Given this list of marker genes Ccr1l1, Col6a1, Acvr2b, Sbds, Fosl2, Tmem38b, Pth1r, Pthlh, Bglap2, Comp, Ccn1, Runx2, Nfe2, Axin2, Matn1, Lox, Mef2c, Sox9 (NCBI Gene Id 70015, SRY (sex determining region Y)-box 9), Suv39h1, Tent5a, Aspn, Icmt, Ptgs2, Mgp, Acvr2a, Mia3, Gcm2, Ddr2, Adgrv1, Wnt11, Csf1r, Nfix, Bmp2k, Ostn, Fgfr2, Dnm3os, Lgr4, Wnt4, Txlng, Zmpste24, Asxl2 (NCBI Gene Id 75302), Gpc3, Actn3, Cd276, Fgfr3, Nbr1, Gpnmb, Ccr1, Smad3, Fzd9, Lep, Ift80, Fam20c, Gata1, Enpp1, Alpl, Ltf, S1pr1, Atp2b1, Hif1a, Duox2, Eif2ak3, Snx10, Pkdcc, Rxrb, Slc24a3, Twist1, Alox5, Col1a2, Lncpint, Prickle1, Ano6 (anoctamin 6), Cyp27b1, Sgms2, Atf4 (activating transcription factor 4), Phospho1, Ecm1, Minpp1, Bglap3, Ccdc154, Cer1, Gja1, Ercc2, Ank, Bglap, Slc20a2, Rflna, Fbn2, Asgr2, Tfap2a, P2rx7, Ltbp3, Pth, Alox15, Igf1, Vdr, Bmpr1b, Dlk1, Mepe, Ifitm5, Grem1, Gla, Srgn, Osr2, Ibsp, Notum, Acvr1, Spp1, Hoxa3, Clec3b, Mtss1, Rspo2, Phex, Fgr, Bmpr2, Nell1, Fgf23, Slc8a1, Sbno2, Ptn, Gpm6b (glycoprotein m6b), Bmp7, Fbxl15, Adrb2, Bmp6, Bmp4, Trpm4, Fkrp, Kl, Rflnb, Herc1, Rxra, Cst5, Smpd3, Isg15, Bcor, Rogdi, Wnt10b, Bmpr1a, Osr1, Bmp2, Ahsg, Atraid, Mmp13, Ptk2b, Klf10, Tcf7l2, Tmem119 (transmembrane protein 119), here is a description of the gene set: species: Mus musculus The deposition of hydroxyapatite, a form of calcium phosphate with the formula Ca10(PO4)6(OH)2, in bone tissue. Mouse Gene Set: GOBP_BONE_MINERALIZATION